The following is a description of a gene set: Human Gene Set: GOBP_LONG_CHAIN_FATTY_ACID_BIOSYNTHETIC_PROCESS species: Homo sapiens The chemical reactions and pathways resulting in the formation of a long-chain fatty acid. A long-chain fatty acid has an aliphatic tail containing 13 to 22 carbons., and this is the list of marker genes: GSTP1, PTGS2, ELOVL5, CYP2C8, ALOX15, CYP1A2, FADS2, GPX4, ASAH2, GSTM1, ALOX5, HSD17B4, ELOVL2, ACSBG2, GSTM4, CYP3A4, ACOT7, ABCD2, ALOX12B, ACSL4, ACOX1, ALOX12, CYP2D6, PLP1, QKI, TMEM135, CYP2C9, GSTM2, FADS1, CYP1A1, ALOXE3, ELOVL6, LTC4S, EHHADH, ALOX15B, ABCD1, ACSBG1, SCP2, ACOT8, CYP2E1